The following is a description of a gene set: studied in species Mus musculus The developmental process pertaining to the initial formation of an endocardial cushion. The endocardial cushion is a specialized region of mesenchymal cells that will give rise to the heart septa and valves. Mouse Gene Set: GOBP_ENDOCARDIAL_CUSHION_FORMATION, and this is the list of marker genes: Snai1, Tgfb1, Bmp5, Bmp4, Snai2, Tbx20, Dchs1, Bmpr1a, Msx1, Aplnr, Bmp2, Bmp7, Smad4, Heyl, Tgfb3, Acvr1, Notch1, Tgfbr1, Robo1 (NCBI Gene Id 436378), Tbx2, Hey1, Robo2, Tgfbr2, Tmem100, Fgf8, Tgfb2, Nog, Rbpj, Eng, Msx2, Tbx3